The following is a description of a gene set: studied in species Mus musculus Mouse Gene Set: GOBP_MORPHOGENESIS_OF_EMBRYONIC_EPITHELIUM The process in which the anatomical structures of embryonic epithelia are generated and organized., and this is the list of marker genes: Cluap1 (NCBI Gene Id 76779), Zic2, Sec24b, Fzd3, Kat2a, Epb41l5, Irx3, Stil, Ift122, Scrib, Arhgap35, Llgl2, Slc39a12, Tctn1, Kif20b, Sufu, Med12, Six4, Wnt5a, Wnt9b, Lias, Vangl2, Lrp2, Aldh1a2, Tulp3, Kdm2b, Sulf1, Zfp568, Brpf1, Sfrp1, Brd2, Ift57 (NCBI Gene Id 73916), Luzp1, Celsr1, Sall4, Rarg, Cobl, Stk4, Pcdh8, Aldh1a1, Gata3, Mir216b, Shank3, Hs2st1, Bmp4, Lmo4, Setd2, Nckap1, Gdf7, Trim71, Cited2, Ovol2, Tsc2, Tead2, Nodal, Grhl2, Twist1, Mir217, Rala, Rock2, Rab23, Pax3, Abl2, Tmed2, Osr1, Hand1, Gli2, Map3k7, Plxnb2, Ift52, Hectd1, Grem1, Mthfd1, Lrp6, Spint2, Stk3, Fuz, Hes5, Kdm2a, Bmp7, Hif1a, Cecr2, Casp8, Wnt2, Irx1, Sox9, Lama5, Fgf8 (fibroblast growth factor 8), Wnt4, Smarca1, Adm, Ar, Rdh10, Alx1, Jag2, Sfrp2, Mthfr, Sox11, Cc2d2a, Nup50, Specc1l, Bcl10, Fgfr2, T, Ift172, Tgfb1i1, Opa1, Cfl1, Gatad2a, Mthfd1l (NCBI Gene Id 77586), Dvl2, Fzd6, Ctnnb1 (catenin beta 1), Kdm6a, Dvl1, Mir216a (NCBI Gene Id 387212), Rgma, Arid1a, Ptch1, Tfap2a, Ipmk, Zeb2, Kdf1, Prickle1, Grsf1, Vegfc, Sox8, Enah, Tbx18, Aldh1a3, Sema4c, Shroom3, Pdx1, Irx2, Lhx2, Sdc4, Pax8, Coq7, Cdk20, Wdr83, Glmn, Wnt6, St14, Prkaca, Bmp5, Shh, Htt, Pax2, Tgfb1, Mib1, Fgf10, Gdnf, Wnt2b, Rps7, Hhex, Pals1, Mks1, Hnf1b, Zic5, Folr1, Phactr4, Prkacb, Apaf1, Bbs4, Trp63, Traf6, Cthrc1, Sall1, Abl1, Nog, Tsc1, Wnt7b, Pfn1, Tgfb2 (NCBI Gene Id 98738), Vasp, Tgif1, Casp3, Grhl3, Ptk7, Dlc1, Spint1, Six1, Ret, Ski, Deaf1, Rara